Given this list of marker genes Zfp640, Gna13, Braf, Wdpcp, Adipor2, Hyal2, Bag4, Gna12, Akap12, Akt1, Aqp1, Itgb1bp1, Slc8a1, Itgb1, Zeb2, Tfap2a, Prr5l, Acta2, Fgf2, Rffl, Uts2, Nherf1, Thbs1, Pak3, Mmp1a, Coro1c, Arhgap4, Appl2, Cygb, Actr3, Rac1, Ptk2 (NCBI Gene Id 14083), Apc, Appl1, Cln3, Cripto, Ager, Sdc4 (syndecan 4), Mta2 (NCBI Gene Id 23942), Tgfb1, Macir, Itgb3, Prkce, Fgfr1, Fer, Pdgfb, Has1, Ddr2, Dmtn, Pak1, Tsc2, Rcc2, here is a description of the gene set: Mouse Gene Set: GOBP_REGULATION_OF_FIBROBLAST_MIGRATION Any process that modulates the rate, frequency or extent of fibroblast cell migration. Fibroblast cell migration is accomplished by extension and retraction of a pseudopodium. studied in species Mus musculus